The following is a description of a gene set: from publication Chen Y, Wang X (PMID 31504780) Genes predicted to be targets of miRBase v22 microRNA hsa-miR-3191-3p in miRDB v6.0 with MirTarget v4 prediction scores > 80 (high confidence targets). Human Gene Set: MIR3191_3P species: Homo sapiens, and this is the list of marker genes: PPP1R9B, EPB41L1, KCTD15, SLC12A5, TRAM1, RAB11B, FN3K, SLC34A1, CALU, ATP11A, GTPBP2, RAX, NFIX, NFIB, LIF, GABRG3, FBLN1, SHISAL1, E2F5, RGS9BP, HBEGF, CPT1B